The following is a description of a gene set: Genes predicted to be targets of miRBase v22 microRNA hsa-miR-5189-5p in miRDB v6.0 with MirTarget v4 prediction scores > 80 (high confidence targets). Human Gene Set: MIR5189_5P studied in species Homo sapiens from publication Chen Y, Wang X (PMID 31504780), and this is the list of marker genes: SSH2, SIKE1, FAM120C, APBB2, SMAD6, FOXP4, FBXL20, NRP1, JRK, SRFBP1, TRMT13, DAB2IP, NBPF4, SIDT1, EGR3, IFI35, ACP6, CACNA1I, BTRC, RARB, CHL1, SMPD1, TFB1M, GABRA1, SPRTN, PDK1, HOXA13, PHF21A, LARP1, COL4A5, NECTIN1, GAB2, GPR62, NF2, YTHDF1, CCNT1, PLEKHM1, NUDT19, AQP2, TPI1, IPO9, LRRC31, IFT122, PTGES3L, WWC2, SPSB4, PRR14L, GPI (NCBI Gene Id 2821), MIER3, FGF14, ZNF609, RD3, DCTN5, PPP3CB, CCP110, SLC17A5, HIVEP3, TRABD2B, RPL28, ANGPT4, SAR1A, CEACAM7, SYNGR1, ORAI2, FAM124A, ABCB8 (NCBI Gene Id 11194), ARF6, CXXC4, NPLOC4, KCNB1, C1orf210, PLOD1, NFAM1, MARCKSL1, SEC63, ATP8A1 (NCBI Gene Id 10396), HAPSTR1, SLC22A14 (NCBI Gene Id 9389), NAT8L, RIMS4, CRTC1, ARNT2, NLRP14, NOS1, TMEM127, TCTN3, SC5D, FOXP1, TMEM41B, RYBP, LRRTM3, FMOD, KPNA6, CMTR2, GIPC3, ZNHIT6, CKAP4, RBMS2 (NCBI Gene Id 5939), EEF2K, FBXO33, CMKLR1, SEC14L1, TANGO2, AHI1, PGAP2, FMO5, CREB5, GDNF, YEATS2, LRRC41, KDM2B, YAP1, SLC6A4, RC3H1, PSD3, TRPC1, TFAP2A, PODNL1, SRR, AKAP13, CAV1, NDOR1, RAB11FIP3, ARRDC3, MUL1, SUDS3, DDX11, ZNF322, PRND, GRK6, BRPF3, PTEN, NXF1, GUCD1, PADI3, TTC22, APPBP2, ZBTB8B, KCNK2, PALM2AKAP2, PPP2R2B, NUFIP2, TUB, RORC, RMI1, SLC25A12